Given this list of marker genes En1, Glrb, Clcn3, Axin1, Idua, Agtpbp1, Mecp2, Ccnd2, Kalrn, Mapt, Grin1, Trh, Hoxd9, Ntsr1, Ntan1, Snca, Prex2, Fgf14, Scn8a, Arcn1, Pmp22, Shank2, Inpp5f, Hoxd10, Npc1, Drd2, Tmod1, Pbx3, Dab1, Nr4a2, Rnf170, Park7, Nlgn2, Adam22, Chl1, Cxcl12, Fxn, Uchl3, Sez6l, Efnb3, Chat, Ntf5, Oprd1, Fgf12, Vps13a, Abl2, Ppt1, Ndufs4, Glra1, Gbx1, Tbce, Cstb, Cln8, Scn1a, Htra2, Cacnb4, Cacna1c, App, Hoxb8, Atp1a3, Ctns, Wdr47, Bc1, Grin2d, Arrb2, Tsc1, Zmpste24, Trmt1l, Id2, Fkrp, Abhd12, Pafah1b1, Kcnma1, Prkn, Kcnj10, Cend1, Oxr1, Sptbn4, Zic1, Sncg, Foxa2, Ngf, Tuba1a, Klhl1, Drd4, Uchl1, Mir23a, Tshr, Cdh23, Mir96, Dmrt3, Gigyf2, Atg7 (autophagy related 7), Hipk2, Btbd9, Gip, Ulk4 (NCBI Gene Id 74372), Pum1, Cacna1a, Epha4, Lgi4, Sez6, Cntn2, Atxn1, Dmbx1, Chd7, Eps8, Cnp, Otog, Slitrk6, Pcdh15, Hexa, Enpp1, Sez6l2, Atp1a2, Drd1, here is a description of the gene set: Mouse Gene Set: GOBP_ADULT_LOCOMOTORY_BEHAVIOR Locomotory behavior in a fully developed and mature organism. species: Mus musculus